Given this list of marker genes Cav1, Exoc7, Exoc2, Itgav, Fuca2, here is a description of the gene set: Any process that modulates the frequency, rate or extent of entry of bacterium into host cell. species: Mus musculus Mouse Gene Set: GOBP_REGULATION_OF_ENTRY_OF_BACTERIUM_INTO_HOST_CELL